The following is a description of a gene set: from publication Chen Y, Wang X (PMID 31504780) studied in species Mus musculus Genes predicted to be targets of miRBase v22 microRNA mmu_miR_7678_3p in miRDB v6.0 with MirTarget v4 prediction scores > 80 (high confidence targets). Mouse Gene Set: MIR_7678_3P, and this is the list of marker genes: Etv1, Kansl1l, Abcc5, Pcdh7, Acvr2a, Trnt1, Esrrb, Tnfaip1, Zfyve16, Ugdh, Osbp2, Cenpo, Tbc1d16, Chmp5, Slc35a3, Niban1, Vgll3, Trib2, Sgcg, Nsd2, Arglu1, Zcchc14, Man2a1, Zfp704, Igsf11, Plppr4, St18, Sesn3 (NCBI Gene Id 80293), Pcif1, Hecw1, Spsb1, Btbd3, Cldn11, Cdc73, Ncam2, Traf5, Pabpc5, Nedd9, Nfia, Zdhhc20, Hrh1, Zmym2, Psmc6, Ets1, Tpt1, Ndfip2, Dnajc6, Ube2q1, Etnk1, Zfp558, Cyp7a1, Anks1b, Rgs22, Chic1, Atosb, Cenph, Sin3a, Postn, Myoz1, D3Ertd751e, Hecw2, Zfc3h1, Lrch3, Rbm46, Dnajb12, Magi1 (NCBI Gene Id 78178), Dgkb, Mcm5, Gopc, Cept1 (NCBI Gene Id 99942), Rskr, Phf21a, Esrrg, Ctsc, Gtf2a1, Zfp646, Dnajc5g, Ankrd12, Trmt12, Satb1, Myoz3, B3galt6, Zdhhc15, Tmem170b, Shtn1, Phactr2, Fbxo33, Zmym4, Phip, Cnot6l, Srsf2, Chordc1, Dus1l, Phf6, Bbs5, Hsf5 (heat shock transcription factor family member 5), Nck2, Cntd1, Fgf12, Marcks, Cacna1e, Peli1, Ppp3ca, Psip1, Ubr1, Stx17, Trim33, Klhl20, Nemp2, Gng12, Nipal1 (NIPA-like domain containing 1), Zfp1006, Tshz3, Tmod2, Srd5a1, Dbx1, Dyrk1a, Rnf152, Rorb, Ascc3, Cadm2, Abl2, Ppargc1a, Gria2, Wdr17, Zfp518a, Cbll1, Smarca1, Otog, Ptbp3, Cdh11, Pcdh19, Otud7b, Kif5b, Pgm2l1 (phosphoglucomutase 2-like 1), Fndc3c1 (NCBI Gene Id 333564), Nacc2, Phf14, Scyl3, Nbeal1, Zfp846, Plxna2, Ap3m1, Zfp236, Mospd2, Slc35f5, Baiap2l1, Rfx7, Smarcc2, Mosmo, Aldoc, Cap2, Atxn1, Aebp2, Trpm3, Mylk4, Mecp2, Usp14, Kat6b, Ebag9, Bnc1, Rora, Cox6a2, Kif14, Map3k13, Ginm1, Suv39h2, Marf1, Atp6v1g3, Acsl1, Ormdl1, Hoxa5, Rcbtb2, Ntrk2, Fez2, Esyt2, Plek, Hnrnpr, Med13, Mael, Dgkk, Celf4, B3gnt5, Ipcef1 (interaction protein for cytohesin exchange factors 1), Mphosph8, Ahcyl2, Asxl2, Grin2a, Lrrn3, Kcnc2, En1, Myct1, Irag1, Trps1, Zswim4, Nup153, Hsd17b11, Atp2b3, Lhx2, Kpna4, Eml1, Ino80c, Epas1, Fermt2, Tmem18, Pik3ca, 2510009E07Rik, Wwp1, Lmo3, Nup160, Chd7, Eif1b, Pik3ip1, Met, Hpf1, Tanc2, Srpk2, Atp10a (NCBI Gene Id 233286), F11, Gnb1, Tmem26, Frrs1l, Intu, Faxc, Spta1, Ubn2, Septin2, Tgfb2, Lats1, Atg5, Baiap2, Aak1, Dimt1, Nucks1, Usp9x, Cyfip1, Plxdc2 (plexin domain containing 2), Slc8a1, Pax9, Or51ab3, Sc5d, Vip, Rps6ka1, Eomes (eomesodermin), Plpp3, Grm1, Specc1, Mpped2, Foxn1, Phf12, Ano3, Klf11, Pprc1 (peroxisome proliferative activated receptor, gamma, coactivator-related 1), 1700123O20Rik, Nek6 (NCBI Gene Id 80473), Epha4, Tcf4, Ust, Map3k2, Zfx, Tut7, Pld6 (NCBI Gene Id 194908), Arl14ep, Pard3b, Pbx3, Sesn1, Msantd5l, Ttc14, Arl5b, Sec23b, Lamc1, Zfp14, Aqp4, Rad51, Pclaf, Ddx3x, Blmh, Heph, Pon2, Cmip, Fut9 (NCBI Gene Id 14348), Caprin1, Usp8, Pdcd6ip, Lmx1a, Serpine1, Pde7a, Sh3pxd2a, Hoxb7 (NCBI Gene Id 15415), Cilk1, Igf1, Ago1, Stk39, 1110032F04Rik, Acan, Sned1, Bicd1, Mtmr10, Plag1, Arhgap6, Deptor, Cep170, Slc35f3, Tpp2, Hhip, Calcb, Cnot4, Tnrc6b, Mtcl3, Ppp2r5e, Fchsd2, Map3k3, Fdx1, Kmt2a, Marchf2, Gnai2, Ctdspl2, Foxn2 (NCBI Gene Id 70776), Fam222b, Ckap4, Tet2, Cdk6, Pcmtd1, Dpp8, D630045J12Rik, Tfap2b, Glis3, Nol9, Cpsf7, Tm6sf1, Fblim1, Cox7a2l, Mtcl1, Cdkn1b, Samd5, Avl9, Srebf1, Themis, Lin9, Tacr1, Pkn2, Tmem231, Nol4, Fbxl17, Pabpc4 (poly(A) binding protein, cytoplasmic 4), Galc, Atp8a1, Pip5k1a, Cetn1, Tab2, Slc41a2, Epha5, Hoxa11 (NCBI Gene Id 15396), Edem1, Psg19, Ptpn3, Kmt5b, Afap1l1, Kifap3, Phb1, Tiprl, Mier1, Msmo1, Etfa, Amer2, Zfp654, E2f4, Pabpc1, Rfk, Fbxo42, Arrdc3, Nufip2, Camk4, Wdr90, Psmd11, Ndufs5, Twist1, Adam22, Casz1, Rps6ka6, Myh2, Tob2, Stk17b, Ankra2